Given this list of marker genes TNS2, TAF2, RRAS2, CTDSPL2, ATP6V1F, BTN1A1, UBE3A, B4GALT5, RGS8, PKLR, SCUBE3, ZNF354A, GAP43, LRRC18, CDCA7, STX1B, ARMH3, SRY, DPYSL4, TMEM39A, KLHL11, NRG3, ACOD1, ITGA10, CALR, ADAMTS4, TSHZ3, KRT32, TTPA, CMIP, NLRP5, BCAM, CFAP77, MTX3, BMPER, BRINP2, KCNB1, SIPA1L3, NLGN2, CPSF7, CLDN12, SMARCC2, LUZP1, WASF2, MBTD1, RC3H2, ASB15, NHS, JADE1, NEGR1, DLX3, MAX, SV2C, ABCA1, RFTN1, CAPN11, FEZ1, ABHD4, SMARCE1, UBE2O, MLLT11, TP63, FAM13A, ZCCHC14, FXR1, ATOSB, MFN2, ASB9, RPL37, PDYN, DPY19L2, SV2A, here is a description of the gene set: studied in species Homo sapiens Human Gene Set: MIR4721 Genes predicted to be targets of miRBase v22 microRNA hsa-miR-4721 in miRDB v6.0 with MirTarget v4 prediction scores > 80 (high confidence targets). from publication Chen Y, Wang X (PMID 31504780)